The following is a description of a gene set: Human Gene Set: HP_APLASIA_HYPOPLASIA_INVOLVING_THE_METACARPAL_BONES Aplasia/Hypoplasia involving the metacarpal bones studied in species Homo sapiens Aplasia or Hypoplasia affecting the metacarpal bones., and this is the list of marker genes: DDR2, BMP2, RTL1, TWIST2, SOX9 (NCBI Gene Id 6662), FANCI, TRPS1, POR, WNT7A, MEG3, SRY, EXT1, FGFR1, CANT1, GNAS, RSPRY1, RPS6KA3, LTBP3, PEX7, COG4, TRIP11, PPOX, SVBP, GPX4, ACVR1, XRCC2, SLC26A2, RNU4ATAC, HDAC8, POC1A, ANAPC1 (anaphase promoting complex subunit 1), TBX5, NIPBL, FANCD2, CCN2, FZD2 (NCBI Gene Id 2535), COMP, DLK1, PORCN, MEGF8, RAD21, BGN, MYSM1, ADAMTSL2, COL11A2, BMPR1B, TP63, SETBP1, HHAT, FLNA, ASXL2, ROR2 (receptor tyrosine kinase like orphan receptor 2), RIPK4, GNAS-AS1, SHOX, CLDN16, PRMT7, NHS, SMC1A, PTCH1, PTHLH, DONSON, COL9A3, B3GLCT, LAMA5, IHH, HDAC4, TGDS, EXT2, RAB33B, FLNB, GLI3, EXTL3, GDF5, SLC39A13, LONP1, RAB3GAP2, FGF16, CWC27, SALL4, CD96, RECQL4, DNA2, PTH1R, FERMT1, TRIO, FAT4, BRD4, ERI1 (NCBI Gene Id 90459), HOXA13, CHSY1, PRKAR1A, INPPL1, NPR2, SHH, PCYT1A, XYLT1, PCNT, PDE3A, FIG4, PDE4D, DYM, DCHS1, SRCAP, FBXL3, RUNX2, SIL1, SMC3, PIK3CD, SMARCA2, RAB23, CHST3, IFT80, MAP3K7, TBX3, STX16, ROBO1, EIF4A3, B3GALT6, LBR, PHYH, REV3L, COL9A1, KNSTRN, PIGS, COL2A1, KCNJ2, P3H1, TAF6, LMBR1, VAC14, VPS13B, BPNT2, SF3B4, VPS35L (NCBI Gene Id 57020), PRKG2, FBN1 (fibrillin 1), DNMT3A, HOXD13, NOG, MATN3, RMRP, NEPRO, PLXND1, IFT52